Given this list of marker genes PRODH2, PRODH, ALDH4A1, here is a description of the gene set: studied in species Homo sapiens part of: Metabolism of amino acids and derivatives Reactome Pathway: Proline catabolism Proline is catabolized in two steps to yield L-glutamate gamma-semialdehyde, which can react further with glutamate to yield ornithine and alpha-ketoglutarate (annotated as a reaction of amino acid synthesis and interconversion) or with NAD+ to yield glutamate and NADH + H+.